Given this list of marker genes Cyp4a31, Ttc39d, Sar1b, Ptpn11, Lpcat3, Anxa2, Cyp4a10, Hrh3, Galr1 (NCBI Gene Id 14427), Ces1a, Acsl4, Ces1g, Apoa1, Itgb3, Kdm5b, Mfn2, Abcg4, Fabp3, Irak1, P2ry2, P2rx7, Ces1e, Pla2g3, Scp2, Gdf9, Triap1, Ces1h, Nkx3-1, Tnfsf11, Osbpl6, Akt2, Runx1, Fis1, Bmp6, Ptges, Spp1, Ecrg4, Atp5pf, Ntsr1, Abcg1, Nr1h3, Prelid1, Itgav, Mapk9, Apoa4, Acsl5, Cav1, Gal, Atp8a1, Naxe, Trem2, Prkcd, Apoc1, Ces1d (carboxylesterase 1D), Abcb4, Hbp1, Pla2g6, Nucb2 (NCBI Gene Id 53657), Ldlrap1, Syk, Egf, Agt, Nus1, Cyp4a32, Sstr4, Dennd5b, C1qtnf1, Agtr2, Irs2, Cyp2j5, Ces1b, Pcsk9, Shh, Pla2r1, Ttc39b, Akt1, Lipg, Yjefn3, Abca5, Surf4, Pon1, Apoc2, Crh, Oxt, Apoe, Edn1, Retn, Apoc3, Crhr1, Arv1, Fasl, Ren1, Pomc, Tspo, Cry1, Il1b, Myb, Gps2, Pla2g10, Mif, Nr1h2, Ces1f, Tnfrsf11a, Dab2 (disabled 2, mitogen-responsive phosphoprotein), Sirt1 (NCBI Gene Id 93759), Eepd1, Igfbp3, Apoa2, Lrat, Pparg, Tmf1, Abca8b, Prap1, Cry2 (cryptochrome circadian regulator 2), Atp8a2, Repin1, Avpr1b, Pla2g4a, Tac1, Abca13, Abca7, Nfkb1, Ces1c, Tmem30a, Il1a, Tmem97, Lrp1, Commd1, Nrg1, Sec24a, Acsl1, Apoc2l, Dbi, Eprs1, Erfe, Kcnk9, Abca8a, Nfkbia, Agtr1a, Nmb, Thbs1 (NCBI Gene Id 21825), Abca1, Acacb, Map2k6, Zdhhc8, Ghrl, Abca3 (ATP-binding cassette, sub-family A member 3), Ptch1, Washc1, Hrh2, Abca2, Cyp19a1, Lamtor1, Furin, Acsl6, Pltp (NCBI Gene Id 18830), Srebf2, Xrcc4, Abca12 (NCBI Gene Id 74591), Adipoq, here is a description of the gene set: species: Mus musculus Mouse Gene Set: GOBP_REGULATION_OF_LIPID_TRANSPORT Any process that modulates the frequency, rate or extent of the directed movement of lipids into, out of or within a cell, or between cells, by means of some agent such as a transporter or pore.